The following is a description of a gene set: Any process that decreases the rate, frequency or extent of the SMAD protein signaling pathway. species: Mus musculus Mouse Gene Set: GOBP_NEGATIVE_REGULATION_OF_SMAD_PROTEIN_SIGNAL_TRANSDUCTION, and this is the list of marker genes: Dkk1, Smad7, Pin1, Xbp1, Pin1rt1, Tgfbr3, Lrp1, Smad6, Nog, Ski, Ccn3, Fam89b, Cilp, Ovol2, Ldlrad4, Pparg, Eid2, Veph1, Grem1 (NCBI Gene Id 23892), Pmepa1, Tbx20, Emilin1, Ucma, Gdf15